Given this list of marker genes Clec4g, Fcgr2b, Dusp22, BC037156, Slamf1, Muc4, Il27ra, Smad7, Tnfrsf14, Cr2, Il20rb, Hfe, Ahr, Jak3, Cd80, Zbtb7b, Ceacam1, Ufl1, Pdcd1, Il2, Samsn1, H2-M3, Ptpn6, Ndfip1 (Nedd4 family interacting protein 1), Zc3h12a, Foxp3, Susd4, Spn, Ascl2, Trim27, Cr1l, Ptprc, Zp3r, Tbx21, Tnfsf4, Nckap1l, Klrd1, Il1rl1, Vsir, Parp3, Tnfsf18, Rc3h2, Nod2, Alox15, Pf4 (platelet factor 4), Foxj1, Rc3h1, Il7r, C4bp, Lilrb4a, Cd274, Ifnb1, Arg1, Lilrb4b (NCBI Gene Id 14727), Loxl3, Ppp3cb, Lgals1, Cd69, Il33, Bcl6, Havcr2, Cd46, Cd160, Il4ra, Il4i1, Il4, here is a description of the gene set: Any process that stops, prevents, or reduces the frequency, rate, or extent of an adaptive immune response. species: Mus musculus Mouse Gene Set: GOBP_NEGATIVE_REGULATION_OF_ADAPTIVE_IMMUNE_RESPONSE